Given this list of marker genes RB1, FAM83A, TWF2, YWHAH, BPY2B (NCBI Gene Id 442867), SOX4, RHOF, GLCCI1, CHD7, MYT1, LIN28A, BPY2, SETD2, DERL1, MAPT, RAI2 (NCBI Gene Id 10742), QSER1, DCLK1, BPGM, CREB1, NRG1, SUMO1, CDC27, GNAS (GNAS complex locus), RD3, BMPR2, BTBD1, MPC2, TSKU, TBC1D5, MAP6, BSPRY, RNFT1, DRAM2, SARM1, PTER, HERC1, WIZ, TEX36, CNTNAP4, BPY2C, ERF, TLK2, ARK2N, MOCS1, SAMD12, CCDC80, MPHOSPH9, here is a description of the gene set: Human Gene Set: MIR7108_5P species: Homo sapiens Genes predicted to be targets of miRBase v22 microRNA hsa-miR-7108-5p in miRDB v6.0 with MirTarget v4 prediction scores > 80 (high confidence targets). from publication Chen Y, Wang X (PMID 31504780)